The following is a description of a gene set: Mouse Gene Set: GOBP_POSITIVE_REGULATION_OF_TRANSCRIPTION_OF_NOTCH_RECEPTOR_TARGET The activation of transcription of specific genes as a result of Notch signaling, mediated by the Notch intracellular domain. studied in species Mus musculus, and this is the list of marker genes: Maml1, Maml3, Maml2, Rbpj, Notch1, Rbm15